Given this list of marker genes E2f1 (NCBI Gene Id 13555), Atf5, Trib3, Egln3, Ddit3, Nr4a1, Sgpl1, Bid, here is a description of the gene set: Mouse Gene Set: RAMJAUN_APOPTOSIS_BY_TGFB1_VIA_MAPK1_DN Transforming growth factor-beta (TGFbeta)-activated signalling pathways can lead to apoptosis, growth arrest or promotion of malignant behaviour, dependent on cellular context. The molecular mechanisms involved in TGFbeta-induced apoptosis remain controversial; although changes in gene expression are thought to be pivotal to the process, several different candidate apoptotic initiators and mediators have been proposed. Smad4, a critical component of the TGFbeta-induced transcriptional machinery, is shown here to be essential for induction of apoptosis. Gene expression analysis identified the proapoptotic Bcl-2 family members, Bmf and Bim, as induced by TGFbeta, dependent on both Smad4 and p38 function and the generation of reactive oxygen species. TGFbeta-induced Bmf and Bim localize to cellular membranes implicated in apoptosis. Inhibition of the TGFbeta-induced expression of both these proteins together provides significant protection of cells from apoptosis. The TGFbeta-triggered cell death programme thus involves induction of multiple BH3-only proteins during the induction of apoptosis. species: Mus musculus from publication Ramjaun AR, Tomlinson S, Eddaoudi A, Downward J (PMID 16909112) Apoptotic genes dependent on MAPK1 and down-regulated in AML12 cells (hepatocytes) after stimulation with TGFB1.